Given this list of marker genes Cd47, Jam3, Ccr2, Pdgfd, Jaml, Plcb1, Sirpa, Ager, Pecam1, here is a description of the gene set: species: Mus musculus Mouse Gene Set: GOBP_MONOCYTE_EXTRAVASATION The migration of a monocyte from the blood vessels into the surrounding tissue.